Given this list of marker genes Mrtfb, Creb1, Myf5, Mir214, Myog, Ctnnb1, Shh, Hmgcr, Mef2c, Prkaa1, Myod1, Lmod3, Usp2 (ubiquitin specific peptidase 2), Dll1, Shox2, Flot1, Mtm1, Myf6, Igf2, Erbb3, Wnt3a, Adrb2, Gja1, Bcl2, Rps6kb1, Actn3, Cdon (cell adhesion molecule-related/down-regulated by oncogenes), here is a description of the gene set: Any process that activates, maintains or increases the rate of muscle development. Mouse Gene Set: GOBP_POSITIVE_REGULATION_OF_MUSCLE_ORGAN_DEVELOPMENT species: Mus musculus